The following is a description of a gene set: Miosis Human Gene Set: HP_MIOSIS species: Homo sapiens Abnormal (non-physiological) constriction of the pupil., and this is the list of marker genes: KIF1B, DDC, TUBB3, PEX7, SIX6, PHOX2A, TUBA1A, LMO1, NOTCH2NLC, HACE1, ERCC6, TUBB2B, PHYH, DNMBP, STIM1, PHOX2B, KIF21A, CHRDL1, LIN28B, ORAI1, GNB2, HHAT, COL25A1, RAB18, MYCN (MYCN proto-oncogene, bHLH transcription factor), ITPR1, ALK